The following is a description of a gene set: Genes down-regulated in the uteri of ovariectomized mice 6 h after progesterone injection: HOXA10 knockout vs wild type animals. species: Mus musculus Human infertility and recurrent pregnancy loss caused by implantation defects are poorly understood. Hoxa-10-deficient female mice have severe infertility and recurrent pregnancy loss due to defective uterine implantation. Gene expression profiling experiments reveal that Hoxa-10 is an important regulator of two critical events in implantation: stromal cell proliferation and local immunosuppression. At the time of implantation, Hoxa-10 mediates the progesterone-stimulated proliferation of uterine stromal cells. Hoxa-10 mutants express a stromal cell proliferation defect that is accompanied by quantitative or spatial alterations in the expression of two cyclin-dependent kinase inhibitor genes, p57 and p15. Hoxa-10 deficiency also leads to a severe local immunological disturbance, characterized by a polyclonal proliferation of T cells, that occurs in place of the normal progesterone-mediated immunosuppression in the periimplantation uterus. Human Gene Set: YAO_HOXA10_TARGETS_VIA_PROGESTERONE_DN from publication Yao MW, Lim H, Schust DJ, Choe SE, Farago A, Ding Y, Michaud S, Church GM, Maas RL (PMID 12554760), and this is the list of marker genes: YWHAG, HOXA11, TP53INP2, CDKN2B, COL15A1, PCP4, QSOX1, ALPL, ACTA1, G6PD, FN1, AOC1, DSG2, GJA1, HOXA10, ALDH1A2, TGFBR3, FST, HOXA11-AS, PIGR